Given this list of marker genes HS2ST1, PIK3CD, KNSTRN, PIGN, THOC6, here is a description of the gene set: Height of the vermilion of the medial part of the lower lip more than 2 SD below the mean. Alternatively, an apparently reduced height of the vermilion of the lower lip in the frontal view (subjective). species: Homo sapiens Human Gene Set: HP_THIN_LOWER_LIP_VERMILION Thin lower lip vermilion